Given this list of marker genes CSAD, SHMT1, CBS, ENSG00000274276 (NCBI Gene Id 102724560), GLDC, AMT, SCLY, AGXT, GCSH, CDO1, SDSL, SDS, THNSL2 (threonine synthase like 2), here is a description of the gene set: The chemical reactions and pathways resulting in the breakdown of amino acids of the serine family, comprising cysteine, glycine, homoserine, selenocysteine and serine. Human Gene Set: GOBP_SERINE_FAMILY_AMINO_ACID_CATABOLIC_PROCESS studied in species Homo sapiens